Given this list of marker genes Atp5mj, Ubap2l, Creg1, Thumpd1, Cpsf2, Coa3, Kif1c, Bmal1, Pigx, Gnb1, Adpgk, Cbr1, Csrp1, Sprr2a1, Diaph3, Pitx2, Nop10, Padi2, Ggh, Tubb6, Cnn3, Ctsc, Flot1, Sqor, AU020206, F2r, St6galnac4, Tspan8, Nfya, Nsdhl, Ccr2, Mrps7, Gatm, Alad, 4833420G17Rik, Trappc12, Spg21, Necap2, Runx1, Cd59a, Psmb6, Itln1, Gemin5, Glo1, Myl10, Ccl9 (C-C motif chemokine ligand 9), Ifi202b, Mtif2, Il3ra, Clec16a, Ifi205, F5, Eloa, Sc5d, Ccnd2, Acadl, Cux1, Prdx2, Nsmce3, Mup3, D2hgdh, Hars1, Snhg1, Gpi1, Nvl, Usp38, Nub1, Med1 (mediator complex subunit 1), Atp6v1b2, Vamp4, Cbfa2t2, Adgrg1, Ttc7b, Dap3, Arl6ip1, Myom1, Rcn1, Cd1d1, Mrpl35, Cnih1, Tm2d3, Gatad2a, Psmg4, Hdc, Gfer, Tfpi, Mpc2, Saraf, Spast, Fgf3, Gnb4, Atad1, Zc3h11a, Emp1, Dbi, Pon2, Nabp1, Hjurp, Rpl26, Srp9 (NCBI Gene Id 27058), Npl, Snhg6, Ocel1, Ptprv, Ptprf, Ddost, F11r, Mtmr9, Cst3, Pdxdc1, Litaf (LPS-induced TN factor), Cryz, Agtrap, Tbcb, Myo5a, Cd1d2, Ggnbp2, 6330403K07Rik, Rgcc, Aldh9a1, Tmem234, Hypk, Ctse, Padi4, Dctn6, Zmym6, Tubgcp4, Fli1, Gcsam, Vps52, Lig3, Dpp7, H2-Ea, Tmco1, Scoc, Mpo, Snrpb2, Ifi204, Msh5 (NCBI Gene Id 279936), Ifi203, here is a description of the gene set: We combined large-scale mRNA expression analysis and gene mapping to identify genes and loci that control hematopoietic stem cell (HSC) function. We measured mRNA expression levels in purified HSCs isolated from a panel of densely genotyped recombinant inbred mouse strains. We mapped quantitative trait loci (QTLs) associated with variation in expression of thousands of transcripts. By comparing the physical transcript position with the location of the controlling QTL, we identified polymorphic cis-acting stem cell genes. We also identified multiple trans-acting control loci that modify expression of large numbers of genes. These groups of coregulated transcripts identify pathways that specify variation in stem cells. We illustrate this concept with the identification of candidate genes involved with HSC turnover. We compared expression QTLs in HSCs and brain from the same mice and identified both shared and tissue-specific QTLs. Our data are accessible through WebQTL, a web-based interface that allows custom genetic linkage analysis and identification of coregulated transcripts. Transcripts in hematopoietic stem cells (HSC) which are cis-regulated (i.e., modulated by a QTL (quantitative trait locus) in close proximity to the gene). from publication Bystrykh L, Weersing E, Dontje B, Sutton S, Pletcher MT, Wiltshire T, Su AI, Vellenga E, Wang J, Manly KF, Lu L, Chesler EJ, Alberts R, Jansen RC, Williams RW, Cooke MP, de Haan G (PMID 15711547) Mouse Gene Set: BYSTRYKH_HEMATOPOIESIS_STEM_CELL_QTL_CIS studied in species Mus musculus